Given this list of marker genes CHEK1, CSNK1G2, BUB1, PKN1, PLK1, CHUK, TTK, CDK2, AKT1, NADK, PRKX, CDK1, MAPK10, NEK2 (NIMA related kinase 2), ECHS1, MAPK6, CDK5, NT5C2, ULK1 (unc-51 like autophagy activating kinase 1), MARK3, CDK4, CDK3, MAPK14, PRP4K, MAP3K7, CDC7, DYRK1A, BUB1B, here is a description of the gene set: Human Gene Set: MODULE_303 Genes in the cancer module 303. studied in species Homo sapiens